The following is a description of a gene set: Mouse Gene Set: GOBP_POST_EMBRYONIC_CAMERA_TYPE_EYE_MORPHOGENESIS studied in species Mus musculus The process in which the anatomical structures of the eye are generated and organized during post-embryonic development., and this is the list of marker genes: Mir23a, Bax, Kdr, Hmgn1, Bak1, Flt1